Given this list of marker genes MGP, SBDS, LBR, EBP, DNAJC21, COL10A1, SLC26A2, BMPER, SRP54, here is a description of the gene set: Abnormal rib ossification studied in species Homo sapiens Human Gene Set: HP_ABNORMAL_RIB_OSSIFICATION An anomaly of the process of rib bone formation.